Given this list of marker genes TMSB10, TMSB4X, S100A6 (S100 calcium binding protein A6), RPL39, ACYP1, RPL26L1, ATP1A2, H2AC8, FAU, here is a description of the gene set: Human Gene Set: YANAGISAWA_LUNG_CANCER_RECURRENCE species: Homo sapiens from publication Yanagisawa K, Tomida S, Shimada Y, Yatabe Y, Mitsudomi T, Takahashi T (PMID 17551146) BACKGROUND: Among patients with non-small-cell lung cancer (NSCLC), those with poor prognosis cannot be distinguished from those with good prognosis. METHODS: Matrix-assisted laser desorption-ionization mass spectrometry was used to analyze protein profiles of 174 specimens from NSCLC tumors and 27 specimens from normal lung tissue and to derive a prognosis-associated proteomic signature. Frozen resected tissue specimens were randomly divided into a training set (116 NSCLC and 20 normal lung specimens) and an independent, blinded validation set (58 NSCLC and seven normal lung specimens). Mass spectrometry signals from training set specimens that were differentially associated with specimens from patients with a high risk of recurrence (i.e., who died within 5 years of surgical treatment because of relapse) compared with those from patients with a low risk of recurrence (i.e., alive with no symptoms of relapse after a median follow-up of 89 months) were selected by use of the Fisher's exact test, the Kruskal-Wallis test, and the significance analysis of microarray test. These signals were used to build an individualized, weighted voting-based prognostic signature. The signature was then validated in the independent dataset. Survival was assessed by multivariable Cox regression analysis. Proteins corresponding to individual signals were identified by ion-trap mass spectrometry coupled with high-performance liquid chromatography. All statistical tests were two-sided. RESULTS: From 2630 mass spectrometry signals from specimens in the training cohort, we derived a signature of 25 signals that was associated with both relapse-free survival and overall survival. Among stage I NSCLC patients in the validation set, the signature was statistically significantly associated with both overall survival (hazard ratio of death for patients in the high-risk group compared with those in the low-risk group = 61.1, 95% confidence interval = 8.9 to 419.2, P<.001) and relapse-free survival (HR of relapse = 11.7, 95% CI = 3.1 to 44.8, P<.001). Proteins corresponding to signals in the signature were identified that had various cellular functions, including ribosomal protein L26-like 1, acylphosphatase, and phosphoprotein enriched in astrocytes 15. CONCLUSIONS: We defined a mass spectrometry signature that was associated with survival among NSCLC patients and appeared to distinguish those with poor prognosis from those with good prognosis. Genes defining a 25-signal proteomic signature associated with a high risk of cancer recurrence and poor survival of NSCLC (non-small cell lung cancer) patients.